Given this list of marker genes Sdc1, Pdcd6ip (NCBI Gene Id 97504), Tsg101, Sdcbp, Stam, Cd34, Sdc4, here is a description of the gene set: species: Mus musculus The aggregation, arrangement and bonding together of a set of components to form an extracellular vesicular exosome, a membrane-bounded vesicle that is released into the extracellular region by fusion of the limiting endosomal membrane of a multivesicular body with the plasma membrane. Exosomes are defined by their size, which generally ranges from 30 nm to 100 nm. Mouse Gene Set: GOBP_EXTRACELLULAR_EXOSOME_ASSEMBLY